The following is a description of a gene set: Human Gene Set: GOMF_ORGANIC_ANION_TRANSMEMBRANE_TRANSPORTER_ACTIVITY studied in species Homo sapiens Enables the transfer of organic anions from one side of a membrane to the other. Organic anions are atoms or small molecules with a negative charge which contain carbon in covalent linkage., and this is the list of marker genes: SLC5A8, CTNS, SLC39A5, SLC2A10, MFSD2A, SLC39A8, MFSD10, SLC26A8, BEST2, FABP3, SLC26A9, SLC27A5, SLC35B2, SLC17A6, SLC37A1, SLC66A1, SLCO1C1, SLC25A5, GRIN2B, ABCC2, SLC47A1, SLC10A3, ABCC1, SLC6A5, SLC37A2, SLCO4C1, SLC25A39, SLC52A1, NHERF1, FABP4, FABP2, SLC6A9, SLC39A12, SLC25A17, SFXN3, SLC39A10, ABCG2, SLC3A2, ABCD2, ABCC4, SLCO1A2, SLC27A1, GRID1, SLC26A10P, UCP2, ABCD4, GRIK3, GRIN2C, SLC6A12, SERINC3, SLC26A4, SLC16A6, GRIN3A, SLC15A4, SLC26A5, SLCO3A1, SLC25A2, SLC6A6, SLC35A1, SLC66A1LP, SLC38A4, GRIK2 (glutamate ionotropic receptor kainate type subunit 2), SLC6A1, BEST4, SLC22A14, SLC16A9, SLC44A4, ANKH, SLC2A3, SLC16A8, SLCO1B3, SLC2A8, SLC1A4, SLC25A26, SLC4A5, SLC16A14, GRIA2, SLC36A4, SLC22A1, SLC36A2, SLC7A5, SLC4A9, SLCO6A1, ABCB11, SLC16A4, MFSD12, SLC22A11, SLC16A10, SLC2A2, MPC1L, SLC5A6, SLC10A5, SLC38A9, SLC4A1, SLC17A5, GRIK5, SLCO1B3-SLCO1B7, SLC6A13, GRIN3B, SLC38A8, SLC25A18, SLC25A13 (NCBI Gene Id 10165), SLC25A44, SLC39A14, CFTR, SLC7A14, SLC7A7, SLC36A3, SLC38A1, SLC38A6, SLC51A, SLC36A1, GRID2, SLC38A3, SLC10A6, SLC35D2, SFXN1, SLC4A11, SLC2A14, SLC19A2, SLC25A6, RTBDN, GRIN1, SLC4A7, SLC23A2, ASIC3, SLC25A31, ABCD1, SLC35B3, SLC33A1, SLC25A42, SLCO4A1, SLC52A3, SLC16A2, ABCB1, SLC38A10, SLC52A2, SLC13A2, SLC32A1, SLC26A3, SLC22A2, SLC23A1, SLC25A19, SLC46A2, SLC4A4, SLC10A1, SLC25A47, TSPO2, SLC25A23, SLC25A16, GRIK4, SLC3A1, SLC25A22, SLC6A11, GRIN2A, SLCO5A1, SLC6A7, MPC2, SLC46A1, SLC25A29, SLC26A6, ABCD3, AKR1C4, SLC16A3, SLC22A6, SLC43A2, GRIK1, SLC7A8, SLC39A6, SLC1A3, FABP5, SLC35D3, SLC26A2, SLC38A2 (solute carrier family 38 member 2), SLC7A9, SLC37A3, SLC7A10, SLC4A8, SLC27A2, SLC25A40 (solute carrier family 25 member 40), SLC26A11, SLC25A41, SLC22A9, SLC16A11, GRIA4, CEACAM1, SLC27A6, SLC1A2, SLC22A3, SLC25A24, SLC25A38, SLC2A6, SLC1A1, SLC7A1, PANX1 (pannexin 1), SLC35D1, SLC38A11, SLCO2B1, CD36, SLC16A5, SLC7A3, SLC16A12, SLC25A10, SLC16A13, SLC7A13, SLC6A20, SLC17A8, SERINC5, SLC35B1, SLC26A1, SLC51B, SLC6A14, SLC22A8, SLC1A5, SLC13A5, SLC38A5, SLC27A4, SLC7A6, SLC6A15, SLC25A12, SLC16A1 (solute carrier family 16 member 1), SLC13A3, SLC1A6, SLC4A3, SLC25A11, SLC5A12, MPC1, SLC25A15, SLC7A11, SLCO1B7, SLCO2A1, SLC39A4, SLC17A3, SLC17A7, SLC4A10, SLC37A4, SLC6A8, SLC25A4, SLC35B4, SLC2A1 (NCBI Gene Id 6513), TMEM241, ABCC5, SLC22A13, SLC25A25, PDPN, SLCO1B1, SLC17A9, SLC25A1, ABCC11, GRIA1, SLC43A1, LRRC8A, GRIN2D, SLC38A7, ABCC3, SLC22A7, GJA1, SLC35A3, SLC16A7, SLC25A21, SLC19A1, SLC10A2, SLC43A3, SLC26A7, SLC10A4, SLC4A2, GRIA3 (glutamate ionotropic receptor AMPA type subunit 3), SLC7A2, SFXN5, BEST1, SLC25A32, SLC1A7